Given this list of marker genes NR4A2, WNT9B, WNT3, RYK, SFRP1, CTNNB1, LMX1A, SFRP2, WNT5A, CSNK1D, LRP6, WNT3A, FZD1, WNT1, RAC1, WNT2, DKK1, here is a description of the gene set: The process in which a relatively unspecialized cell acquires the specialized features of a midbrain dopaminergic neuron. Human Gene Set: GOBP_MIDBRAIN_DOPAMINERGIC_NEURON_DIFFERENTIATION species: Homo sapiens